Given this list of marker genes RPS28, CCDC47, ZC3H12A, SRPRA, SEC61A2, RPL27, SEC63, ALG5, GNRH1, MACO1, SEC61A1, ARL6IP1, SEC61B, SEC61G, UBA1, SRPRB, SUCO, PLOD2, PLOD1, RPS26, SSR4, TMEM97 (NCBI Gene Id 27346), PI4KB (NCBI Gene Id 5298), RP9, RPS29 (NCBI Gene Id 6235), SRP9, EPM2A, here is a description of the gene set: species: Homo sapiens The lipid bilayer surrounding the rough endoplasmic reticulum. Human Gene Set: GOCC_ROUGH_ENDOPLASMIC_RETICULUM_MEMBRANE